Given this list of marker genes Reck, Timp3, Rhbdf2, Mbp, Stat3, here is a description of the gene set: studied in species Mus musculus Any process that modulates the frequency, rate or extent of metalloendopeptidase activity. Mouse Gene Set: GOBP_REGULATION_OF_METALLOENDOPEPTIDASE_ACTIVITY